The following is a description of a gene set: studied in species Homo sapiens Human Gene Set: GSE14000_UNSTIM_VS_16H_LPS_DC_UP Genes up-regulated in comparison of dendritic cells (DC) before and 16 h after LPS (TLR4 agonist) stimulation. Dendritic cells (DCs) are the sentinels of the mammalian immune system and they undergo a complex maturation process mediated by activation upon pathogen detection. Recent studies described the analysis of activated DCs by transcriptional profiling, but translation regulation was never taken in account. Therefore, the nature of the mRNAs being translated at various stages of DC activation was determined with the help of translational profiling, which is the sucrose gradient fractionation of polysomal-bound mRNAs combined to microarrays analysis. Total and polysomal-bound mRNA populations were compared in immature (0h) and LPS-stimulated (4h and 16h) human monocyte-derived DCs with the help of Affymetrix microarrays. Biostatistical analysis indicated that 296 mRNA molecules are translationally regulated during DC-activation. The most abundant biological process among the regulated mRNAs was protein biosynthesis, indicating the existence of a negative feedback loop regulating translation. Interestingly, a cluster of 17 ribosomal proteins were part of the regulated mRNAs, indicating that translation may be fine-tuned by particular components of the translational machinery. Our observations highlight the importance of translation regulation during the immune response, and may favour the identification of novel gene clusters or protein networks relevant for immunity. Our study also provides information on the possible absence of correlation between gene expression and real protein production in DCs. from publication Ceppi M, Clavarino G, Gatti E, Schmidt EK, de Gassart A, Blankenship D, Ogola G, Banchereau J, Chaussabel D, Pierre P (PMID 19943945), and this is the list of marker genes: BRD3, KIAA0930, GPAA1, VPS45, IL16, RPL7A, ATP5MJ, SMIM19, PYROXD2, LIMS1, MOSPD1, PRKX, RPL29, COX7C, HADH, SHB, DMAC1, CTNS, GAS7, YIPF1, CCNB1IP1, DGAT1, FOXJ2, JTB, CTNNBIP1, ERCC8, TMEM14C, TMEM245, ARL3, SLC26A2, SATB2, TRAPPC2L, PRADC1, ACP6, SMDT1, ARL2, LINC02035, ARHGAP9, PECAM1, NDUFS3 (NCBI Gene Id 4722), SLC25A44, CUTA, MBNL1, CCDC86, CMTM4 (NCBI Gene Id 146223), NDUFB1, USP22, RPL27A, BRI3BP, HS2ST1, FAM168B, INPP5K, NDRG3, UQCRH, ZMYM3, MPG (N-methylpurine DNA glycosylase), NOL9, CROT, BLCAP, MAP2K5, SLC12A9, GPRASP2, LSM10, CHD9, TRIT1, DEPTOR, ABHD10, NCLN, VSIR, KIF9, LRRC8A, CRYL1, MRM2, SEPTIN9, SASH3, VCL, TXN2, PTGS1, SPCS3, RPS13, TUBGCP2, NICN1, FH, GAS2L1, ESRRA, PMFBP1, PFAS, RNF166, SNHG29, DTWD1, IL27RA, HACD2, UQCC5, SYNJ2BP, ATP5PB (ATP synthase peripheral stalk-membrane subunit b), ARL6IP4, IFT20, SCARB1, IRAG2, PTDSS1, MICOS10, FGFRL1, IL17RA, CARD9, C15orf61, ARMC10, OIP5-AS1, ESYT1, STK32C, TTC3, HSBP1, PLEKHG4, COPS3, PIP4K2B, CYB5R1, TRIB2, TCFL5, TIMM9, CD33, EIF4EBP2, CISD1, GIT2, ATP5PD, SMARCD2, ATP2A3, KAT8, TUFM, IDE, GAS2L3 (NCBI Gene Id 283431), TCTN3, HAUS4, RAB4A, KIAA2013, EMB, MTARC1 (mitochondrial amidoxime reducing component 1), KATNB1, TSPAN32, ATXN1, RAB31, ZCCHC24, LINC00957, SKAP2, DGKH, HOMER3, MAP3K3, EPRS1, RXRA, RPL22, INPP5A, SUOX, PLXNB2, VPS37B, ST13, MYG1, PABPC4, TNFRSF10D, TIGAR, NDUFAF8, NDUFB6, MAPKAPK3, UQCR10, FZD2, MAPK9, GBA2 (glucosylceramidase beta 2), ZNF252P, ZMAT3, PANK3, KLHL8, QPRT, ZBTB8A, RPL26L1, STYXL1, TPST2, MOB3B, AGO2, PREPL, EIF3K (eukaryotic translation initiation factor 3 subunit K), MAP1A (NCBI Gene Id 4132), ITPRIPL1, SNX29, RPL13A, RIN3, PARVG, STX10, PSMG3, TMED10, STARD3, SNX5, TBL1XR1, PRDM15, LINC00324, MKKS, CCNY, TMEM126A, CAMK1, RPL19, LRMDA